The following is a description of a gene set: from publication Yevshin I, Sharipov R, Kolmykov S, Kondrakhin Y, Kolpakov F (PMID 30445619) Genes containing one or more binding sites for (CASP8AP2) in their promoter regions (TSS -1000,+100 bp) as identified by GTRD version 20.06 ChIP-seq harmonization. Human Gene Set: CASP8AP2_TARGET_GENES studied in species Homo sapiens, and this is the list of marker genes: SSBP1, H2AC12, FGFR1OP2, MTND1P15 (NCBI Gene Id 100288998), EIF4E2 (NCBI Gene Id 9470), EXOSC3, NOLC1, H2BC14, ATP6V1H, DPM3, CUL4A, ENKUR, SHARPIN, SMG8, METTL15, CHCHD2, HEXA-AS1, ZNFX1, ACE, NR1H2, ADAMTS7P4, C8G, NOL8, H2BC12, PEX3, EXOC8 (exocyst complex component 8), SBF1, ZBTB17, IQCH, AFF4, SCAF11, BBX, DUX4L18, LINC01719, JPX, ARID4B, TTC16 (tetratricopeptide repeat domain 16), FAM98A, ANKRD13A, MRPS23, SF3A3, ADAP2, LAS1L, FRAT1, CFAP221, SELENOW, MYH9, PSTK, ZNF195, VPS25, EXD2, SNX12, DNAJA3, SKIC3, ADAT2, RNU11, MAF1, ETV2, IQGAP1, C3orf38, TRMT2A (tRNA methyltransferase 2 homolog A), SNRPD1, MRPL39, CLIP1, ANKRD26, ENPP3, TOR1AIP1, MRPL16 (mitochondrial ribosomal protein L16), AGBL5, ZNF579, H2BC21, MT-TN, NSFL1C, HSPE1, THNSL1, SNORD43, MTND5P11, EID2B, CDC123, CENPP, ATP8A1-DT, SNAP47, H1-1, RNVU1-6, FBXO31, ZSCAN12 (NCBI Gene Id 9753), TIPIN, INTS12, SEC22B, MRPS24, C17orf75, FAM230G, LSM5, DNAAF3, PLXDC1, EXD3, RNFT1-DT, H1-4, RNF31, STX16, MT-TA, PHB2, MRPL40, INTS13, SNHG3, SUFU, GTF3C5, TOP3B, COMMD2, HELQ, POR, ILF2, FAM98B, WDR31, H2BC11, MTERF4, CCAR2, PCDH15, GGPS1, JMJD4, SREK1IP1, RNFT1, PSCA, CPOX, DAGLB (NCBI Gene Id 221955), H2AC6, MIR142HG, RFX2, COX19, NOXA1, RFC2, RBAK-RBAKDN, CWC27, H2AC14, TLN2, PDE6D, PDCD6P1, SNX16, FABP6, AP3S2, FRA10AC1, POU2F1-DT, TUT1 (NCBI Gene Id 64852), PDRG1, ECE2, POLG, BOLA1, TMEM79, ATP8A1, COX16, HEXA, RNU6-411P, OSGEPL1-AS1, ZFAS1, PCLAF, H1-2, ISY1-RAB43, FRG1FP, COA6-AS1, HIRA, TRIP4, NME1-NME2, CHTOP (NCBI Gene Id 91678), PIK3R3, ARSK, CCDC12, CLCN7, NUDT5, STX16-NPEPL1, RPN2, ALKBH3, NME1, SLC8A1, WEE2-AS1, TIGD1, DSTYK, MT-TY, TARS2, PTPN21, MRPL13, GTF3C3, ZNF276, ZNF12, HSPE1-MOB4, POU2F1, KBTBD4, SAYSD1, H2AC4, TPGS1, ANKHD1, TGIF1, HSPA1A (heat shock protein family A (Hsp70) member 1A), NT5C3A, GRPEL2, PTMS, PDCD2L, TSEN15P3, NCL, MTBP, RPL37, MRPS15 (mitochondrial ribosomal protein S15), H2BC4, RPS7, FBXO33, CASC11, SNRPB2, WDR24, NFX1, STAT1, SEPTIN7, SECISBP2, TMEM101, RANBP1 (NCBI Gene Id 5902), COPS7B, ZNF140, LINC02739, MRPL44, TEFM, ASPHD2, ZMYM4, GLUD1P3, HPS4, MAP1LC3B, AGBL5-AS1, MROH8, KANSL3, MAN2C1, LRRC27, CDC16, NPRL2, CCND3, VPS9D1, RBAK, MITD1, HSPD1, DNAJC25, POLG-DT, FRG1HP, NDUFS3, CGGBP1, CBY1, H4C8, ADPRHL1, MED23, C1GALT1, SCAF4, CLTC, RPL3, HMGXB4, SLC4A1AP (solute carrier family 4 member 1 adaptor protein), PANTR1, FBXW5, NORAD, TMEM242-DT, MKRN3, PSMD3, HSPA1L, SUPT7L, ZNHIT3, UIMC1, KLHL7, SEPTIN7-DT, KNSTRN, PSMF1, PSME2, ISY1, SLC39A13, NDUFC2-KCTD14, RABGGTA, N6AMT1, GSTCD, SPRTN, BMS1, EMG1, BMS1P4, C10orf88, H3C1, RAB23 (NCBI Gene Id 64438), SOS1, DDX11L17, ENSG00000239137, MTCO3P12 (MT-CO3 pseudogene 12), LTN1, GALNT16-AS1, SMG5, ALG10B, KLHL7-DT, EDF1, DNAJC25-GNG10, OSGEPL1, LIMA1, STK32C, H2AC20, TAF8, HUS1, H4C3, MRPS31P5, DDX55, FAM222B, JRK, PTRH1, CCDC57, AP5Z1, CCDC7, MT-TC, MFN2, MRPL30, RPS24, FBXO28, AAGAB (NCBI Gene Id 79719), BZW2, NDUFC2, MRPL58, ALG3, MRPS18C, TMEM167B, DMAP1, TMEM41A, RCC1, H4C2, BMS1P4-AGAP5, VPS51, IPP, COA6, USP30, RAB18, CAAP1, SNORD118, MIR3143, CYB561D2, FUS, SNORD12C, DNTTIP2, ANKMY2, PKIG, PCID2, FAM227A, AFF4-DT, CORO7, USP42, RNA5SP283, SYF2, TMEM242